The following is a description of a gene set: Genes predicted to be targets of miRBase v22 microRNA hsa-miR-513a-3p, hsa-miR-513c-3p in miRDB v6.0 with MirTarget v4 prediction scores > 80 (high confidence targets). from publication Chen Y, Wang X (PMID 31504780) Human Gene Set: MIR513A_3P_MIR513C_3P studied in species Homo sapiens, and this is the list of marker genes: SMARCAD1, CCN3, C7, DCAF10, PPP1R9A, TPRG1, FGFR1OP2, PEX5, LAMTOR3, NAPEPLD, AZIN1, DAZ2, WHAMM, MAGEB4, PHIP, FEM1C, MAP3K4, B4GALNT4, UMAD1, HNRNPK, STXBP5, SPRYD7, UGT2B17, INTS2, BAMBI, LUC7L2, TNPO1, SKIL, ASAP2, TMTC1, MPPED2, SLC7A14 (NCBI Gene Id 57709), CNTN5, COL6A3 (collagen type VI alpha 3 chain), NOP2, ANTXR2, ANKRD17 (NCBI Gene Id 84177), CHCHD7, TTC28, ZFAND5, RAB8B, KIF13A, SLC35F5, YTHDF3, ZFYVE16, PPP2CB, AK2, PARPBP, SH3KBP1, SAR1A, DTWD2, ARFGEF3, JADE1, DISC1, NOTCH2, CD38, PAWR, SEC23A, TDRD15 (NCBI Gene Id 100129278), NUS1, ASB7, XPA (XPA, DNA damage recognition and repair factor), CERK, TMEM170B, SLC12A2, RAD54B, ICA1L, SLC26A2, DEK (DEK proto-oncogene), FMR1, PLEKHG7, PSD2, NUP93, SNX3, ABRAXAS1 (abraxas 1, BRCA1 A complex subunit), DNER, SREK1, ADGRG6, BCL2L13, ZNF516, SP3 (NCBI Gene Id 6670), CCNE2, ZNF326, TMEM106B, IKZF2, EPHA5, NUFIP2, DENND5B, PDE8A, KDM7A, DCUN1D5, TIPRL, LRP6, BRMS1L (BRMS1 like transcriptional repressor), SELENOI, STRN, PPM1E (protein phosphatase, Mg2+/Mn2+ dependent 1E), SNX15, GYPA, MTF2, GTF2H5, KCNS3, GSPT1, RUNDC3B, EDEM1, HLTF, UGT2B4, ENAH, RUFY2, LACC1, C14orf28, PRKACB, TXNDC16, STOX2, TMEM38B, FEM1B, ZNF34, USP31, TBC1D12, CALB1, SH3GLB1, CCDC141, TOP2B, HPCAL4, PCDH11X, CNN3, SYPL1, FBXO33, RICTOR (NCBI Gene Id 253260), RNF6, C5orf24, CACNB4, GCNT1, PAQR5, RFX3, SLC2A13, RPS6KA5, DGKI, ZNF626, VPS37A, BAG4, SAMD8, PPP1R3D, UBE2K, ABI1, MACIR, CDK17, PABPC4L, ABHD13, NEUROG2, NUDT21, NCOA1, CSRNP3, HACE1, LARP4, TOGARAM1, MCOLN2, LIN9, FAM135A, PREX2, ZBTB8A, PTP4A1, ADAM10, LRATD1, TRDMT1, ALCAM, FBXO4, YWHAZ, ITCH, AGFG1, WASF3, PHF20L1, KALRN, PPP4R2, ADAMTS5, HEXIM1, RBM27, TCEANC2, TLCD4, SYT4, MTM1, NRIP1, MDM4, PTPRB, ZBTB21, PDIK1L, MDFIC, TSNAX, ZDHHC21, PRKG1 (protein kinase cGMP-dependent 1), ELF2, SPIRE1, TPMT, AFF4, NCBP1, LIN7C, ZNF287, SLC17A6, TCF12, CADM2, HSPA5, CSGALNACT1, SMIM13, ZDHHC2, SLC39A12, FST, SLC22A5, U2SURP, SERPINB8 (serpin family B member 8), NDUFB8, CCDC50, TBX18, JMJD6, MAL2, NDUFA5, CARF, CCDC39, SGIP1, BICC1, PTEN, RASGRP4, MOB1B, CNOT6 (NCBI Gene Id 60404), PITPNB, DUXA, RBBP5, KLHDC1, ZC2HC1A, ZNF22, GPR180, TRIM33, EFCAB14, CNST, ZNF148, LEPROT, FSBP, SNX14, PCDH8, GOSR2, LRRC3B (leucine rich repeat containing 3B), ACVR2A, KCTD1, FLYWCH1, ZBTB41, CREBZF, WBP4, FAM171B, GABRA4, SLC7A11, MAPK6, ELK4, NEDD4L, CHD7, LSAMP, RSKR, RNF138, ABRAXAS2, FAM118B, ETNK1, OLFM3, OTUD6B, ANGPTL3, RBMS3, GGCX, RETSAT, LRRC4C (NCBI Gene Id 57689), ANGEL2, ZNF320, SPG11, BCL11B, RANBP9 (RAN binding protein 9), NYAP2, ZFP28, UEVLD, GPBP1, PRP4K, CPEB3, CHST9, SCAI, SMARCA1, UBE2D3, RNF103, RASSF8 (Ras association domain family member 8), FUT9, SGPP1, FAS, ACOT13, NAB1, MRC1, BMX, RPS6KB1, DR1, MXI1, RNF146, ITGA4 (integrin subunit alpha 4), TMTC3, HOMER1, TOPORS (TOP1 binding arginine/serine rich protein, E3 ubiquitin ligase), PDE11A, PHF14, PGAP1, TMCO3, SLC4A7, MED13, TARP, SHANK2, APPL1, CREG2, XIAP, MIGA1, RELCH, APOH, BTF3L4, IDS, CNOT6L (NCBI Gene Id 91275), SNX4, RYBP, SLC25A46, PFKFB3, FSD1L, SLC6A4, PEG10, FBXO8, ADAMTSL3, HTR2C, NETO1, ARHGAP29, GNAI3, MINDY3, EIF4A2, ENKUR, PTGDR, MSX1, NT5DC1, HIRA, RXFP1 (NCBI Gene Id 59350), SLFN5, ZFHX4, ARG1, CDK19, ELF1, PPP2R1B, CYBRD1 (cytochrome b reductase 1), DRD1, IGF2BP3, TWF1, RCAN3, CSNK1A1, LHX8, HBS1L, LYPLA1, VPS50, CREB1, ZNF736, SLK, PTPRC, RAPH1, VGLL3, SPOCK3, FAM133A, WDR20, AHDC1, TMF1, KDM6A (NCBI Gene Id 7403), SETD9, PPP3CA, BOLL, RNF111, CUL3, DIPK2A (divergent protein kinase domain 2A), KLF15, ASXL2, G3BP1, CTDSPL2, GPLD1, SGCZ, MAP7, MGST1, SCAF11 (NCBI Gene Id 9169), TRIP12, TXNDC11, ALDH6A1, MATR3, KANK4, JPH4, DLAT, ARL6IP6, RELN, ZNF518B, LANCL3, SLC30A6, ZNF678, SUV39H2, GAB1, XRN1, CEACAM1, PIK3CA, CDH19, MEI4, TOR1AIP2 (torsin 1A interacting protein 2), SOX1, NIPBL, PALS2, SERINC5, SLC1A3, MEIOC, CCDC186, FAM20B, RC3H1, LRP8, SNCA, CXADR, SEMA5A (semaphorin 5A), UFL1, PKP2 (plakophilin 2), LCORL, FUS, IL6ST, HDX, ELOC (elongin C), GASK1B, KLRD1, PPARG, CDC73, FNDC1, MED14, ELAVL2, GOLGA3, ZNF367, RANBP3L, TMEM33, ZCCHC9, ATP11AUN, PHLPP1, TSC22D1, EPDR1 (ependymin related 1), MBNL3, SPRED1, ARMH4, FAM114A1, LRRC7, LIN54, EEA1 (early endosome antigen 1), C18orf54, KCNC2, CHIC1, MBOAT2, CASZ1, DAZ4